Given this list of marker genes Per1, Gimap4, Arpc2, Ikzf1, Dock10, Sphk1, Creb5, Il10ra, Mmd, Anxa2, Ikbkb, Tcf4, Pdlim5 (NCBI Gene Id 99766), Marcks, Cd80, Glipr2, Etv6, Cyfip1, Itga4, Gbp5, Pde4b, Actn1, Lcp1, Xbp1, Fnbp1, Klf6, Pla1a, Ikzf4, Chd7, Cst3, Atp11a, Prps1, Mkrn1, Eif3a, Ktn1, Adprh, Ccr7, Igsf8, Txn1, Akap9, Gcnt2, Tcaf1, Rgs1, Pim1 (NCBI Gene Id 18712), Psd3, Mir155hg, Gsap, P2ry10, Necap2, Rap2a, Nr4a3, Bcl2l11, Tmem131l, Serpinb1a, Ccl17 (NCBI Gene Id 20295), Ccl22, Pik3r1, Tcaf2, Vdr, St14, Jak2, Adra1a, Samhd1, Srgn, S100a11, Scn3a, Clic4, Scimp, Adgrg6, Nuak2, Ccl12, Id2, Tsc22d3, Ints3, Acsl5, Plek2, St8sia4, Zbtb18, Mdfic, Ahnak, Cdkn1a, Rgs12, Ranbp1, Atp2b1, Bzw1, Cd302, Slfn2, Orai1, Coro1c, Calm1, Syngr2, Nfil3, Tagln2, Plgrkt, Large1, Crem, Wipf1, Usp12, Cd86, Gtpbp4, Basp1, Ptpn1, Litaf, Wfdc17, Ly75, Ehd1, Ptger4, Myl12a, Iscu, Tpm4, Abtb2, Nckap1l, Fchsd2, Trim35, Suv39h2, Tbc1d8, Wnk1, Zbp1, Lfng (LFNG O-fucosylpeptide 3-beta-N-acetylglucosaminyltransferase), Ndrg1, Il1rn, Cytip, Rabep1, Slamf1, Cd274, Gpbp1, Selplg, Cacna1d, Plk2, Ggta1, Npr1, Rhoc, Fscn1, Mylk, Trim25, Ncoa7, Pkib, Nup88, Rel, Phactr2, Sft2d2, Bcl2a1d, Cd63, Bcl2a1b, Samsn1, Rab8b, Socs1, Cish, Slc27a3, Atp6v0a1, Cpne3, Vim, Cyrib, Irf5, Coro2a, Mex3b, Cfl1, Dusp5, Actg1, Bcl2a1a, Trim30a, Serpinb6b, Cmtm6, Ifitm2, Flnb, Myh9, Serpina3g, Serpinb9, Pik3r5, Sf3a3, Rasa2, Ifi47, Vopp1, Slc33a1, Plscr1, here is a description of the gene set: from publication Cui A, Huang T, Li S, Ma A, Pérez JL, Sander C, Keskin DB, Wu CJ, Fraenkel E, Hacohen N (PMID 38057668) Mouse Gene Set: CUI_LANGERHANS_IL1B_RESPONSE_UP species: Mus musculus Cytokines mediate cell-cell communication in the immune system and represent important therapeutic targets. A myriad of studies have highlighted their central role in immune function, yet we lack a global view of the cellular responses of each immune cell type to each cytokine. To address this gap, the authors created the Immune Dictionary, a compendium of single-cell transcriptomic profiles of more than 17 immune cell types in response to each of 86 cytokines (>1,400 cytokine-cell type combinations) in mouse lymph nodes in vivo. A cytokine-centric view of the dictionary revealed that most cytokines induce highly cell-type-specific responses. For example, the inflammatory cytokine interleukin-1β induces distinct gene programmes in almost every cell type. A cell-type-centric view of the dictionary identified more than 66 cytokine-driven cellular polarization states across immune cell types, including previously uncharacterized states such as an interleukin-18-induced polyfunctional natural killer cell state. Genes positively differentially expressed in cell type: Langerhans upon treatment with cytokine: IL-1β in mouse lymph nodes in vivo.